Given this list of marker genes GPC6, FCGR1A, DNAJB9 (NCBI Gene Id 4189), GAD2, RAP2C, BMAL2, WDR6, ATAT1, RASA2, PID1, QRSL1, NPFFR2, LILRA2, EPHA5, PGD, DNAJC27, MRPL17, CDC20B, DLGAP4, SLC22A4, WDR83, DIP2C, F9, FAM199X, BRD8, EOLA1, PTPN9, PLEKHA3, GCNT1, TAOK1, AKNAD1, VPS13B, SLC22A7, SOCS2, LARP7, P2RY12, MTDH, TRPA1 (NCBI Gene Id 8989), LACC1, PPP1R14C, SDC4 (syndecan 4), ZNF398, DELEC1, MAP2, MED26, CRYM (NCBI Gene Id 1428), FEZ2, CHKA, PODXL, FST, FCGR1BP, MYO5A, FAM200B, RNF14, YPEL1, NHERF1, PAPPA, PKNOX1, PLAA, UVSSA, FGF11, MDM4, MACIR, ERLIN1, PTPRC, LRP8, ITCH, CUL3, KCTD5, ZNF124, MAPK9, SSPN, PABIR1, RND3, ZNF449, GTF3C4, MAP2K4, PKD2L2, FAS, SH3BGRL2, ARIH1, PPP4R4, SWI5, ZNF716, TNPO2, TSPAN12, TENM1, MAGED1, CDH26, ARHGAP11A, GIMAP4, here is a description of the gene set: species: Homo sapiens Genes predicted to be targets of miRBase v22 microRNA hsa-miR-517-5p in miRDB v6.0 with MirTarget v4 prediction scores > 80 (high confidence targets). from publication Chen Y, Wang X (PMID 31504780) Human Gene Set: MIR517_5P